The following is a description of a gene set: part of: Signaling by NTRK2 (TRKB) Activation of the neurotrophin receptor NTRK2 (TRKB) by BDNF or NTF4 triggers downstream PLCgamma (PLCG1) signaling, resulting in formation of secondary messengers DAG and IP3. studied in species Homo sapiens Reactome Pathway: Activated NTRK2 signals through PLCG1, and this is the list of marker genes: PLCG1 (phospholipase C gamma 1), NTF4, NTRK2, BDNF